Given this list of marker genes Gal3st3, Gal3st4, Gal3st2c, Gal3st1, Gal3st2, here is a description of the gene set: studied in species Mus musculus Catalysis of the reaction: N-acetyllactosamine + 3'-phosphoadenosine 5'-phosphosulfate = 3-sulfo-N-acetyllactosamine + adenosine 3',5'-bisphosphate. N-acetyllactosamine residues are found in a number of different carbohydrate types. N-acetyllactosamine can also be written as Gal-beta-(1,4)-GlcNAc. Mouse Gene Set: GOMF_GALACTOSE_3_O_SULFOTRANSFERASE_ACTIVITY